Given this list of marker genes LNPK, RAB3GAP2, RAB3GAP1, ARL6IP1, TMEM33, here is a description of the gene set: Any process that modulates the frequency, rate or extent of endoplasmic reticulum tubular network organization. Human Gene Set: GOBP_REGULATION_OF_ENDOPLASMIC_RETICULUM_TUBULAR_NETWORK_ORGANIZATION species: Homo sapiens